Given this list of marker genes P4HTM (prolyl 4-hydroxylase, transmembrane), PPIB, ZFX, SP7, TMCO1, YY1, MED12, ERI1, COL6A2, CBL, PRR12, COL6A1, SON, COL13A1, GNB2, ASAH1, COL3A1, CRELD1, PTDSS1, BRAF (NCBI Gene Id 673), ALG2, HYAL1, ECEL1, RSPRY1, SMS, COL5A1, HDAC4, NLRP1, KCNH1, HRAS, FGD1, IFITM5, USP9X, B3GALT6, RAB3GAP2, CSGALNACT1, RPS6KA3, COMP, PIGG, CAMTA1, PLAA, ESAM, COL1A2, PROKR2, SPART, PKDCC, COL6A3, COL12A1, GORAB, FKBP14 (NCBI Gene Id 55033), FBN1, PLOD1, CDK10, COL1A1, NFASC, OTUD6B, TRPV4, KMT2A, RNF13, PYCR2, LMX1B, PYROXD1, PUF60, here is a description of the gene set: Small joint hypermobilty studied in species Homo sapiens The capability that a small joint (or a group of joints) has to move, passively and/or actively, beyond normal limits along physiological axes. Small joints include metacarpophalangeal joints, proximal interphalangeal joints, \nsecond to fifth metatarsophalangeal joints, and wrists. Human Gene Set: HP_SMALL_JOINT_HYPERMOBILTY